The following is a description of a gene set: Generation of second messenger molecules Mouse Gene Set: REACTOME_GENERATION_OF_SECOND_MESSENGER_MOLECULES studied in species Mus musculus, and this is the list of marker genes: Trac, Cd3e, Trav19, H2-Eb2, Cd101, Pak1, Nck1, Lck, Cd247, Trbv16, Itk, H2-Ea, Trbv15, Fyb1, H2-Aa, Cd3g, Pak2 (NCBI Gene Id 77101), Plcg2, Trav16, Cd3d, Zap70, Cd4, H2-Eb1, Pak3, Lat, H2-Ab1, Grap2, Plcg1, Lcp2